The following is a description of a gene set: species: Homo sapiens Human Gene Set: GSE36476_YOUNG_VS_OLD_DONOR_MEMORY_CD4_TCELL_40H_TSST_ACT_DN Genes down-regulated in comparison of memory CD4 T cells from young donors treated with TSST at 40 h versus those from old donors treated with TSST at 40 h. from publication Yu M, Li G, Lee WW, Yuan M, Cui D, Weyand CM, Goronzy JJ (PMID 22434910) With increasing age, the ability of the immune system to protect against recurring infections or to control chronic infections erodes. The objective of the current study was to identify gene expression signatures in elderly CD4 T cell responses, and this is the list of marker genes: HACD1, ERCC3, RNF114, KCNN4, SEC31A, DPM2, NPEPPSP1, HEXIM1, EGR3, LMBR1L, GON4L, ATP6AP1 (NCBI Gene Id 537), H2BC12 (H2B clustered histone 12), COX8A, DAP, ZSWIM8, ZNF274, GPS1, UPP1, HIVEP1, PRKCA, P3H1, ECHS1, SOS2, NEFL, ERMAP, CDK11A, CLIC1, ALDH2, TBC1D8, NOD2 (NCBI Gene Id 8135), GADD45B, BLTP1, ZFYVE21, HLA-DQA1, ZNF202, APEH, CSRNP2, MYD88, NID2, KIAA0408, LRPAP1, SEC23A, NCOR2, MAGT1, BSCL2, SSNA1, FAM204A, H4C11, PI4KA, ADTRP, DHRS3, PMM1, BABAM1, SLC25A38, COMMD10, LAGE3, VTI1B, RAF1, ZSCAN32, ZNF337, C1D, METTL9, SIRT7, ZNHIT3, ACYP2, MPI, NAP1L2, MRPS15, CBY1, NFKBIE, SNRPD2, TGFBR3, ACVR1, MAD1L1, PTGER2 (NCBI Gene Id 63381), GCC1, ANKLE2, CREG1, C11orf21, TYK2, EPHX2, LUC7L, CLK2, CALM3, PBX3, RHOC, KANK1, TXK, SYNGR2, SQSTM1, F2R, MBD1, NCK2, FAM13A, MICAL1, MYL12A, HDAC4, UBR2, PRKCD, FHIT, BCL6, EXT2, PRKCZ, H2AZ2, STK38, TBC1D1, CSTB, PSMB4, BCKDK, PIAS3, DNAJB14, AMIGO2, TNFRSF1B, MEF2A, TUSC2, UCKL1, FLII, SLC35G2, DMAC2, EYA3, YY1AP1, MAP4K4, BCAR3, RAB33A, SMUG1, EIF3F, TPD52L2, PRKAB1, HLA-DMA (major histocompatibility complex, class II, DM alpha), SPRED2, RALGDS, MAP3K14, PLEKHA1, SERPINB9, NFKB2, PLEKHB1, ZNF133, GARRE1, IL7, RPL9, TFIP11, RBM6, TRIP12, GATAD1, CDK5, RASSF1, CHSY1, GTPBP8, MED23, BCR (BCR activator of RhoGEF and GTPase), CCDC22, COX6A1, PDCD6, HINFP, PI4K2A, ZC3H7A, ACP5, TTN, POLR2G, ABHD3, GRAMD1C, DGUOK, TRAF3, TALDO1, P4HTM (prolyl 4-hydroxylase, transmembrane), SURF1, PAF1, GATD3, ATP2A2, DAPK1, INTS9, ZNF189, CDK17, PLPP1, DOP1A, TSC22D3, UGCG, WASF2, RPS20, UBASH3A, ZNF266, ACOT7, BID, ATP11A, EGR1, VAMP1, VASH2, POMZP3, TMEM168, SLC15A3, GSTM4, CREB3L2, GRK5, NDUFS3, ATP11B, LIN7B